Given this list of marker genes RRAGA, SZT2, NPRL3, NPRL2, DEPDC5, here is a description of the gene set: A GTPase-activating protein (GAP) complex that regulates TORC1 signaling by interacting with the Rag GTPase. In human, the GATOR1 complex consists of DEPDC5, NPRL2, and NPRL3. In S. cerevisiae, this complex is referred to as SEACIT and contains the Iml1p, Npr2p, and Npr3p proteins. studied in species Homo sapiens Human Gene Set: GOCC_GATOR1_COMPLEX